The following is a description of a gene set: The presence of moderately increased concentrations of albumin in the urine, defined as and albumin-creatinine ratio (ACR) of 30 to 299 mg/gm (3.4 to 34 mg/mmol). studied in species Homo sapiens Human Gene Set: HP_MODERATE_ALBUMINURIA Moderate albuminuria, and this is the list of marker genes: STAT3, SLC37A4, IER3IP1, GCK, MIA3, AMN, KCNJ11, ABCC8, PDX1, INS